Given this list of marker genes RPS6KA3, MAPKAPK3, NAB1, IRS1, PIK3CB, SHC3, KRAS, AP2B1, MAPK1, VRK3, CRKL, PLCG1, RAP1A, JUNB, MEF2C, PPP2CB, RRAD, RPS6KA5, EGR4, DNM3, CDK5, F3, CDK5R1, SRC, FRS2, FOS, ATF1, DNM1, MAP2K5 (mitogen-activated protein kinase kinase 5), PPP2R1B, PPP2R5D, YWHAB, LYL1, NGF, NTRK2, FOSL1, NRAS, ASCL1, SHC1, ARC, RPS6KA1, RIT2, ADORA2A, FOSB, NTRK1, TCF12, SOS1 (NCBI Gene Id 7838), MAPK11, DUSP3, IRS2, EGR3 (NCBI Gene Id 1960), AP2M1 (adaptor related protein complex 2 subunit mu 1), HRAS, PIK3R2, TPH1, ID3, SGK1, RALA, AP2S1, EGR2, DNM2, RALGDS, RIT1, DUSP4, MAPK12, DNAL4, CDK5R2, CLTA, MEF2A, MAPK3, MAP2K1, ADCYAP1R1, ID1, STAT3, KIDINS220, SH3GL3, AP2A1, AP2A2, MAPKAPK2, MAPK7, SH3GL2, CRK, RPS6KA2, NAB2, VGF, EP300, CREB1, PIK3CA, MEF2D, REST, DUSP7, PPP2R1A, SRF (serum response factor, NCBI Gene Id 6722), CHD4, TRIB1, SHC2, PIK3R1, GRB2, MAP2K2, MAPK13, RAPGEF1, EGR1, ADCYAP1, ATF2, DUSP6, RHOA (NCBI Gene Id 387), ELK1, RALB, MAPK14, JUND, PPP2CA, ID4, CLTC, ID2, BRAF, here is a description of the gene set: Reactome Pathway: Signaling by NTRK1 (TRKA) studied in species Homo sapiens part of: Signaling by NTRKs Trk receptors signal from the plasma membrane and from intracellular membranes, particularly from early endosomes. Signalling from the plasma membrane is fast but transient; signalling from endosomes is slower but long lasting. Signalling from the plasma membrane is annotated here. TRK signalling leads to proliferation in some cell types and neuronal differentiation in others. Proliferation is the likely outcome of short term signalling, as observed following stimulation of EGFR (EGF receptor). Long term signalling via TRK receptors, instead, was clearly shown to be required for neuronal differentiation in response to neurotrophins.